The following is a description of a gene set: studied in species Homo sapiens Any process that activates or increases the frequency, rate or extent of protein polyubiquitination. Human Gene Set: GOBP_POSITIVE_REGULATION_OF_PROTEIN_POLYUBIQUITINATION, and this is the list of marker genes: BIRC2 (baculoviral IAP repeat containing 2), MARCHF7, NOD2, XIAP, SPSB4, NMI, SKP2, GABARAP, UBE2V1 (NCBI Gene Id 7335), PRKN, RIPK2, FBXO4 (NCBI Gene Id 55087), UBE2N, UBE2D1, UBE2V2, DDX3X, PTPN22, HAMP